Given this list of marker genes BAD, CASP3, ARHGEF2, YBX3, TIFAB, USP15, BDKRB2, SCN2A, EPO, PTGS2, here is a description of the gene set: Human Gene Set: GOBP_INTRINSIC_APOPTOTIC_SIGNALING_PATHWAY_IN_RESPONSE_TO_OSMOTIC_STRESS studied in species Homo sapiens The series of molecular signals in which an intracellular signal is conveyed to trigger the apoptotic death of a cell. The pathway is induced in response to changes in intracellular ion homeostasis, and ends when the execution phase of apoptosis is triggered.